Given this list of marker genes Ifi213, Ly6i, Irf7, Trim30a, Mthfd2, Ube2l6, Ifi205, Xaf1, Ifi209, Ifi47, Cxcl9, Sp100, Psme3, Ly6e, Fcgr1, Nod1, Ly6a, Rnf213, Zbp1, B2m, Mndal (NCBI Gene Id 192690), Ifi206, Ifi204, Slfn5, Iigp1, Isg15, Phf11d, H2-K1, Dtx3l, Sema4d, Slfn1, Tmbim6, Srsf9, Cfb, Oasl2, Ap1g2 (adaptor protein complex AP-1, gamma 2 subunit), Ifi27l2a, Pfn1, Phf11b, Clec2d, Oas3, Ifi211, Pnp, Stat1, Ifitm3 (NCBI Gene Id 66141), Ly6c2, here is a description of the gene set: from publication Cui A, Huang T, Li S, Ma A, Pérez JL, Sander C, Keskin DB, Wu CJ, Fraenkel E, Hacohen N (PMID 38057668) Genes positively differentially expressed in cell type: cDC2 (conventional dendritic cell type 2) upon treatment with cytokine: IFN-λ2 in mouse lymph nodes in vivo. Cytokines mediate cell-cell communication in the immune system and represent important therapeutic targets. A myriad of studies have highlighted their central role in immune function, yet we lack a global view of the cellular responses of each immune cell type to each cytokine. To address this gap, the authors created the Immune Dictionary, a compendium of single-cell transcriptomic profiles of more than 17 immune cell types in response to each of 86 cytokines (>1,400 cytokine-cell type combinations) in mouse lymph nodes in vivo. A cytokine-centric view of the dictionary revealed that most cytokines induce highly cell-type-specific responses. For example, the inflammatory cytokine interleukin-1β induces distinct gene programmes in almost every cell type. A cell-type-centric view of the dictionary identified more than 66 cytokine-driven cellular polarization states across immune cell types, including previously uncharacterized states such as an interleukin-18-induced polyfunctional natural killer cell state. Mouse Gene Set: CUI_CDC2_IFNL2_RESPONSE_UP species: Mus musculus